The following is a description of a gene set: studied in species Homo sapiens Human Gene Set: GOBP_NEGATIVE_REGULATION_OF_PROTEIN_MATURATION Any process that stops, prevents or reduces the frequency, rate or extent of protein maturation., and this is the list of marker genes: USP17L2, FGA, CTSZ, PLAU, SERPINE1, GAS1, FURIN (furin, paired basic amino acid cleaving enzyme), SERPINF2, TMEM98, CHAC1, PLAT, IL1R2, SERPINE2, SNX12, GLG1, NLRP7, MIR152, THBS1, SIRT4, MAGEA3, ACP4, MDM2, PRNP, LRRK2, AKT1